The following is a description of a gene set: Mouse Gene Set: GOBP_POSITIVE_REGULATION_OF_CYTOKINESIS Any process that activates or increases the frequency, rate or extent of the division of the cytoplasm of a cell, and its separation into two daughter cells. studied in species Mus musculus, and this is the list of marker genes: Drd3, Spast, Kif3b, Incenp, Tas1r2, Birc5, Prkce, Sstr5, Svil, Tas2r124, Exoc7, Cdc14b, Cenpv, Poldip2, Cdc14a, Cdca8, Cit, Cdc25b, Rxfp3 (NCBI Gene Id 239336), Aurkb, Igf1r, Rab11a, Mrgprb1, Cdc42, Rhoa, Rab11fip3, Wnk1, Nup62, Pkp4, Cdc6, Cul3, Gipc1 (GIPC PDZ domain containing family, member 1), Kif14, Map10, Ect2, Pkn2, Arf6, Drd2, Kif20b, Kif23, Racgap1, Chmp3, Tas2r102, Cxcr5, Cspp1, Tas2r121